Given this list of marker genes OTULINL, RNF152, ELMOD2, GORAB, TBCA, MRPS7, DNAAF9, RNPC3, DENND1B, RAB28, PURA, TMCC3, HECW2, TMEM26, MOB1B, ZNF544, NKAIN2, TASP1, TRPC6, MBNL3, ARHGAP5 (Rho GTPase activating protein 5), KCNAB1, ZNF275, SMIM10L1, ADCY6, AUNIP, GNA13, KMT2C, ZHX1, EIF1AX, BOD1L1, LACC1, RAP2C, PPP4R3B, ZNF280D, APH1B (NCBI Gene Id 83464), NR2F2, SEMA3C, NECAB1, UNC5D, IGSF22, LINC02694 (NCBI Gene Id 400359), METTL4, MATR3, TCF7L2, STK17A, THRB, MED13, ANKRD44, ARHGAP42, DNAJC18, KPNA1, ABI1, FAM217A, KLF12, ARL5B, ANXA4, PTGS1, CYP19A1, ONECUT2, USP46, NCBP2, RIMKLA (NCBI Gene Id 284716), DR1, EIF4E (NCBI Gene Id 1977), ZNF804A, MYH10, MCCC2, EBPL, FAM20C, ARID1B, SP4, PIAS2, ZNF827, CPED1, PCDH19, ITGB1BP1, WBP11, GRM5, CSDE1, TRA2A, VSNL1, HMCN1, PTP4A2, TIPARP, DUSP16, ATXN7L1, MAMDC2, KRT85 (NCBI Gene Id 3891), DTNA, ZMYM6, CNKSR2, FAM135A, NAV3, SMURF1, YWHAG, F2R, NETO1 (NCBI Gene Id 81832), FBXW11, GUF1, THNSL1, SMCO4, CD3G, TAF5L, EIF3A, AGPAT5, FGFR2, RYK, RO60, SMARCC1, XBP1, SKIDA1, CCSER1, CCN1 (NCBI Gene Id 3491), PLCXD3, UPF3A, POU2F1, TAOK3, PRXL2C, MED12L, ARID1A, GUCY1A2, UFM1, RIMKLB, SPTSSB, ARIH1, ATRX, CDC42BPA, CALCR (NCBI Gene Id 799), G3BP2 (NCBI Gene Id 9908), WDSUB1, CLTA, PLXNA4, TNRC6B, MAPRE1, TUT7 (terminal uridylyl transferase 7), CTXN2, SLC1A2, CKS2, BMAL2, CMPK1, POLR2M, SPTBN1, KIF5B, ZIC3 (NCBI Gene Id 7547), TM9SF3, NR3C1, SCML2, CDH20, ASPH (NCBI Gene Id 56921), AEBP2, SLC30A8, TUSC3, DKC1, CHIC1, XPNPEP1, MTCL1, PTGER2, ANKRD42, TBC1D9, SNX30, EXOC5, CPOX, E2F6, MAP9, IKZF2, SEL1L, VCF1, MAP1B, MECOM, CEP135, SOWAHB, ZDHHC17, SNTG1, ACO1, SCN3B, TSC1, TTC39C, DNAJC21, PCMTD1, ARPC5, CFAP184, ASB15, ROR1, ATAD1, MEX3B, OSCP1, UBQLN2, ZBTB20, ODAD2, NPM1, NEGR1, TMEM170B, MTMR3, PTPRG, RPL7L1, E2F5, ZNF37A, MED27, ILF3, TRIM23, DDX3X, DDX3Y, here is a description of the gene set: from publication Chen Y, Wang X (PMID 31504780) Human Gene Set: MIR4420 species: Homo sapiens Genes predicted to be targets of miRBase v22 microRNA hsa-miR-4420 in miRDB v6.0 with MirTarget v4 prediction scores > 80 (high confidence targets).